The following is a description of a gene set: Mouse Gene Set: GOBP_POSITIVE_REGULATION_OF_LEUKOCYTE_MIGRATION Any process that activates or increases the frequency, rate, or extent of leukocyte migration. species: Mus musculus, and this is the list of marker genes: Tmem102, Csf1, Pawr, Mmp9, Fpr2, Selp, Ednra, Ccr6, Perp, Thbs1, Ripor2, Mcu, Thy1, Selenok (NCBI Gene Id 80795), Vegfc, Zfp580, Ccl1, Ccl20, Rhoa (NCBI Gene Id 51787), Il1r1, Cx3cr1, Ascl2, Dapk2, Camk1d, F2rl1, S100a14 (S100 calcium binding protein A14), Pdgfd, Spi1, Cd47, Mapk3, Hmgb1, Tlr2, Jam2, Il12a, Ccl19-ps6, Fpr-rs6, Cd99l2, Cxcr2, Mapk1, Dock8, Csf1r, Fadd, Madcam1, Ccl21f, Trem1, Ccl19-ps1, Med23, Rtn4, Cd74, Lgals9, Ptn, Spn, P4hb, Sele, Ccr1l1, Ptger3, Il4, App, Akirin1, Ppbp, Pecam1, Fpr-rs3, Wnt5a, Tnfrsf14, Il1a, Cxcl13, Vegfd, Itga2b, Ccr2, Ccl21b, Cx3cl1, Wnk1, Edn3, Mstn, Ptk2, C3ar1, Lgmn, Sell, Ano6, Pik3r1, Ccl12, Creb3, Tnfrsf18, C5ar1, Pycard, Ptk2b, Nckap1l, Mia3, Gas6, Ptger4, Ccl19-ps5, Ccr1, Defb25, Ccl5, Icam1, Il1b, Ccl3, Swap70, Rac1, Ptprj, Mospd2, Fut7, Slamf1 (signaling lymphocytic activation molecule family member 1), Mmp14, Mdk, Thbs4, Ptafr, Adora3, Ccr7, Adam17, Tgfb1, Trem2, Edn1, Calr, Il23a, Coro1a, Lyve1, Pgf (placental growth factor), Ccl19-ps3, Fut4 (fucosyltransferase 4), Bdkrb1, Oxsr1, Gpsm3, P2ry12, Vegfb, Myo1f, Itga2, Itgb3, Zp3, Ccl24, Ccl21a, Aoc3, Ccl21d, Dnm1l, Lgals3, Rarres2, Il34, BC037156, P2rx4, Cxcl17, Tirap, Lbp, Cxcl14, Fpr-rs7, Adam8, Aif1, Serpine1 (NCBI Gene Id 231790), F7, Ccl2, Tnfsf18, Rac2, Trpv4, Tacr1, Nedd9, Abl1, Edn2, Tnfsf14, Plvap, Ccl21e, Fpr-rs4, Ccl19, Itga4, Abl2, Cmklr1, Dysf, Ager, Ccl7 (NCBI Gene Id 20306), Tnfsf4, Trp53, Stk39, Cxcl10, Pla2g7, Jam3, Cxcl12, Adam10, Xcl1, Ccl19-ps4, Kitl, C1qbp, Vegfa